Given this list of marker genes Fermt1 (fermitin family member 1), Dek, Myl12b, Polr2i, Mmp7 (matrix metallopeptidase 7), Ucp2, Rps7, Tmem238, Cct2, Rps26, Cyb5b, Sult1d1, Rpl18, Selenoh, Naa38, Id2, Aurkaip1, Rps27, Cd24a, Ndufs6, Ciao2a, Erdr1, Rpl41, Clu (NCBI Gene Id 28201), Arl6ip1, Prdx1, Srsf3, Dpy30, Atp1a1, Ndufc2, Rpl32, Cyb5r3, Sbspon, Hnrnpc, Rnaset2a, Pls3 (NCBI Gene Id 236867), Tecr, Cd9, 1810037I17Rik, Muc1, Tgfbi, Slc39a4 (solute carrier family 39 (zinc transporter), member 4), Cystm1, Mrpl18, Smap1, Cxcl17, Cox7c, Rps15a, Rps2, Arg2, Rps10, Rps27l (NCBI Gene Id 67941), Tubb4b, Lsm8, Eif4h, Snrpf, Rpl12 (ribosomal protein L12), Mphosph8, mt-Nd4, Tbca, Glrx5, Iah1, Nap1l1 (NCBI Gene Id 53605), Id1, Aamdc, F11r, Eef1b2, Lbp, Rps29, Ndufa11, Ormdl2 (NCBI Gene Id 66844), Spc24, Rpl14, Rps28, Rpl26, Npm1, Stmn1, Ndufab1, Anxa4, Dctn3, Micos13, Atp5mk, Serpinb11, Rps13, Sf3b5 (NCBI Gene Id 66125), Ncl, Mrpl14 (mitochondrial ribosomal protein L14), Vdac2, Mrpl12, Ndufb6, Bola2, Mbd3, Set, Atp5pf, Fkbp4, Adi1, Rdh10, Mrps12, Atp5pb, Dhrs4, Atp5pd, Tmem176a, Rad23a, C3, Uqcrb (NCBI Gene Id 67530), Lsm2, Stx18, Polr2j, Ndufa4, Acadl, Rn18s-rs5 (18s RNA, related sequence 5), Rps9, Ssrp1, Rpa3 (NCBI Gene Id 98283), Rps21, Fxyd3, Slirp, Alad, Lcn2, Timm8b, Rbis, Rpl37, Atp5me, Atp5f1c (NCBI Gene Id 80670), Cited4, Psmb5, Gtf2a2, Ndufa8, Bex3, Rps5, Fcgbp, Snrpd2, Coa3, Mrpl57, Rps12, Acp1, Nudt14, Serbp1 (NCBI Gene Id 66870), Pa2g4, Atp5mj, Polr2f, Ndufa7, Ndufa5, Sox17, Ranbp1, Slc1a5, Krt8, Gpx2, Tomm7, Ndufaf2, Ndufa12, Mrpl17, Polr2e, Hnrnpab, Cenpx, Aldh1a1, Lage3, Snrpd1, Plekhs1, Thoc7, mt-Cytb, Cox6c, Mdh1, Tmem213, Ubl5, Uqcrfs1, Gstm7 (NCBI Gene Id 99761), Chchd2, Ndufv2, Snrpe, Ndufb8, Atp5mc1, Yipf1, Rps17, Pfdn1, Ifitm1, Dgat2, Apex1, Pfdn2, Rpl11, Lyar, Pdlim1, Rpl21, Krt19, Rpl27, Tubb5, Pgls, Krt18, Cuta, Hat1, mt-Nd1, Rbm8a, Ltf, Gstm2, Mrpl36, Rpl7, Cox8a, Hjurp, Cdo1, Ivns1abp, Hprt1, Ap1s3, Smim22, Anapc13, Dctpp1, Taldo1, Siva1, Chchd10, Rpl34, Tuba1b, Tuba4a, Mrpl42 (NCBI Gene Id 72550), Dcxr, Tmem176b, Ndufa13, Knop1, Lsm6, Atp5mf, Tmem158, Tspan8, Idh3a, H2az1, Mrpl34, Rpl17, Rpl36al, Emc6, Spint2, Sf3b4, Hspe1, Cox4i1, Dlx5, Rbbp7, Paics, Wfdc2, Prdx6, Arl6ip4, Nop10, Kctd14, Sprr2f, Cox7b, Hspd1, Rfc3, Bbln, Msx1, Cyc1, Ccdc34, Uqcr11, BC048679, Lamp2, Cbr2, Rplp1, Gstm1, Mrpl40, Gclm, mt-Rnr1, Snrpg, Pcna, Krtcap2, Rplp2, Epcam, Cfi (NCBI Gene Id 12630), Grpel1, Snrpd3, C1qbp (complement component 1, q subcomponent binding protein), Mt1 (metallothionein 1), Cldn3, Echdc2, S100g, Dynll2, Slc25a5, Rpl37a, Rps11 (NCBI Gene Id 27207), Uqcr10, Cox7a2, Magoh, Rpl23, Mid1ip1, Egfl6, Ptma, Anp32b, Ldhb, Mif, Phb2, Rpl36, Tipin, Slc25a11, Dut, Pigr, Ifitm3, Ptn, Rps8, Rnf128, Sftpd, Rps27a, Tceal9, Top2a, Mgst1, Ssna1 (NCBI Gene Id 98824), Dtymk, Gstm5, Gsto1, Spink12, Bola1, Skic8, Rpl22, Ndufb4, Mrps14, Psmb7, Pdlim4, Plat, Rn7sk, Cdk4, Bcas2, Cbx6, Hmgn1, Cacybp, Nhp2, Tpt1, Cldn7, Sfxn1, Plet1, Sox9, Hint1, Pmf1, Tmem14c, Atp5if1, Rpl39, Pclaf, Cib1, Mrps6, Cox6b1, Bcat1, Rpl38, Ndufa1, Psma7 (proteasome subunit alpha 7), Arpc5l, Brk1, Gtf3c6, Ran, Rbbp4, Bcam, Wdr83os, Atp5mc3, Cox5a, Rnaset2b, Cox6a1 (cytochrome c oxidase subunit 6A1), Lmnb1, Cisd1, Tonsl, Rpl36a, Rps24, Cks1b, Tle5, Cldn10, 2510002D24Rik, Anpep, Mt2, Ndufa3 (NCBI Gene Id 72213), Trmt112, Ndufa6, Tyms, Hddc2, Banf1, Rnaseh2c, Ndufb2, Txn1, Suclg1, here is a description of the gene set: Table S2: Representative genes of each cell cluster Mouse Gene Set: ZHANG_UTERUS_C13_EPITHELIAL1_CELL from publication Zhang L, Long W, Xu W, Chen X, Zhao X, Wu B (PMID 35669188) studied in species Mus musculus